The following is a description of a gene set: studied in species Homo sapiens The DCC family includes DCC and neogenin in vertebrates. DCC is required for netrin-induced axon attraction. DCC is a transmembrane protein lacking any identifiable catalytic activity. Protein tyrosine kinase 2/FAK and src family kinases bind constitutively to the cytoplasmic domain of DCC and their activation couples to downstream intracellular signaling complex that directs the organization of actin. part of: Netrin-1 signaling Reactome Pathway: DCC mediated attractive signaling, and this is the list of marker genes: CDC42, DCC, RAC1, NTN1, SRC, DOCK1, PTK2, ABLIM2, NCK1, WASL, ABLIM1, ABLIM3, TRIO, FYN (NCBI Gene Id 2534)